Given this list of marker genes FAT4, GLDN, GNPTAB, ALG12, PEX5 (NCBI Gene Id 5830), ROR2, H1-4, FGFR2, PRDM5, ZNF469, GABRD (NCBI Gene Id 2563), GDF5, AMER1, ADAMTS3, DHODH, IDUA, HOXD13, CDC45, MYO9A, DCHS1, PPP2R5D, SCARF2, TUBA1A, RTTN, ASXL1, LGI4, SPEN, DSE, WDR73, NSD1, POLR3GL, COL3A1, IKBKG, FHL1, BLTP1, MET (MET proto-oncogene, receptor tyrosine kinase), IL6ST (interleukin 6 cytokine family signal transducer), FGF8, ERCC6, SPRY4, SLC35A2, LIFR, TBX2, STAC3, BRPF1, TGFB2, PIGL, SMOC1, FZD2, KRT9 (keratin 9), CNTN1, SMS, UPF3B, PHF6, COG1, NOD2, MAGEL2, CCN6 (cellular communication network factor 6), ERCC2, SPART, CHRNG, CANT1, HS6ST1, GPC4, DSP, NUP188, SMAD2, CAPN3, SLC39A13, TRPS1, B9D2, OCRL, JUP, TNNT3 (NCBI Gene Id 8044), TDO2, CHD7, H4C9, DYM, FILIP1, NUP88, CDC42, COL12A1, BCOR, TNNI2, ORC1, TAC3, TP53RK, ITCH, BGN, WNT5A, LUZP1, MEGF8, EMG1, ZMPSTE24 (zinc metallopeptidase STE24), TNNC2, TOR1AIP1, MORC2, HUWE1, PEX2, BHLHA9, ASXL3, LMBRD2, COL6A3, ZNF407, TLK2, MED13L, MEGF10, PROKR2, TGFB3, ALX1, CCBE1, COL1A1, TGFBR2, CSGALNACT1, HES7, YRDC, ALG8 (NCBI Gene Id 79053), ORC4, NSMF, SUZ12, ZC4H2, GNPNAT1, KCNAB2, NAA10, RAB3GAP1, WIPI2, EXOSC5, CTDP1, CDC6, KIF21A, NLRP3, PORCN (NCBI Gene Id 65017), MAPK1, SCN4A, TBR1 (T-box brain transcription factor 1), CHST3, CRLF1, LAGE3, NOG (noggin), GPKOW, THOC6, ADAMTS15, CTCF, MMP2, FBXO28, XYLT1, LAMB3, TGDS, NALCN, MAP3K7 (NCBI Gene Id 6885), PIGA, RAB23, PRDM16, EED, DUSP6, ZEB2, FLVCR1, CLCF1, GNRHR, TPM2, GJA1, MEG3, MYOD1 (NCBI Gene Id 4654), KISS1R, ATPAF2 (ATP synthase mitochondrial F1 complex assembly factor 2), CUL4B, ADAT3, TACR3, ATP6V1A, PEX1, DVL3, NT5C2, PDPN, ARPC4 (NCBI Gene Id 10093), KAT6B, ATAD1, TBC1D2B, NUP107, CACNA1C, SKI, NIPBL, FBN2, EPB41L1, COL11A2, ADAMTSL2, COG8, RIC1, CDT1 (chromatin licensing and DNA replication factor 1), APC2, WDR4, COL11A1, MAFB, SLC26A2, CCDC22, MMP23B, KRT16, MYL11, DPH1, ANTXR2, SALL4, POLR3A, ERI1 (exoribonuclease 1), SMAD3, PHGDH, LFNG, SATB2, FKTN, MAF, IDS, UBE4B, WDR11, CDH3, NHLH2, CCDC32 (coiled-coil domain containing 32), BCR, GORAB, SF3B4, PIEZO2, MYBPC1, NEK9, OSGEP, COL6A2, DPH2, ERCC5, DRG1, IGHMBP2, SHH, ORC6, NR4A2, TBX15, SH3PXD2B, SLC18A3, TOR1A, RAPSN, DOK7, PSMB8, FGD1, DPM1, ECEL1, CRKL, MED25, PRG4, KISS1, DPAGT1, TRPV4, PAX3, SMG9, LMNA, SLC35A3, GNRH1, ATP6V1E1, MYH3, TWIST2, ZIC2, MSL3, ACTG2, ERLIN2, PRKCZ, IPO8, SLC29A3, ERCC1, PLOD3, COL6A1, NXN, DLL3, SMC1A, FGF17, KRT1, SMARCAD1, NEDD4L, MESP2, TCTN3, TMEM70, LMBR1, FERMT1, RPL10, EIF5A, KCNK9, DLK1, RIPPLY2, CDK13, GLI3, CASZ1, GJA8, SETBP1, KDM5B, HINT1, LBR, GPC3 (NCBI Gene Id 6394), POR, TUBB3, ABL1, GON7, PEX6, FGFR3, KLHL7 (kelch like family member 7), RTL1, MUSK, L1CAM, MBTPS2, GMNN, PIGN, TP63, FIBP, CHN1, FLNA, PERP, SMAD4, GJA5, SNX14, FGFR1, DVL1, TPRKB, KIF15, EFNB1, HSPG2, RERE, ARX, TGFBR1, EZH2, NKAP, GLUL, PROK2, MED12, KDM5C, MKS1, COG5 (component of oligomeric golgi complex 5), FBXO11, ARID1B, PQBP1, NUP133 (NCBI Gene Id 55746), TBX3, ALX3, ZDHHC9, FBN1, here is a description of the gene set: studied in species Homo sapiens A bent (flexed) finger or toe joint that cannot be straightened actively or passively. It is thus a chronic loss of joint motion due to structural changes in muscle, tendons, ligaments, or skin that prevents normal movement of joints. Flexion contracture of digit Human Gene Set: HP_FLEXION_CONTRACTURE_OF_DIGIT